The following is a description of a gene set: species: Mus musculus The process in which a relatively unspecialized immature germ cell acquires the specialized features of a mature female gamete. Mouse Gene Set: GOBP_OOCYTE_DIFFERENTIATION, and this is the list of marker genes: Tut4, Rps6ka2, Foxo3, Igf1, Tdrd1, Ctnnb1, Bcas2, Oog1, Dnmt3a, Washc5, Pabpc1l, Wee2, Sohlh1, Ehmt2, Insl3, Zp3, Kmt2d, Sirt2, Pde5a, Zar1l, Pld6, Tdrd6, Ezhip, Tdrd5, Lgr5, Rec8, Tut7, Tdrd7, Zfx, Fbxo5, Ptk2b, Dazl (deleted in azoospermia-like), Nppc, Pde3a (phosphodiesterase 3A, cGMP inhibited), Bcl2, Cdc25b, Dmrt1, Edn1, Ppp2r1a, Oosp2, Kmt2b, Washc1, Npm2, Dnmt3l, Dmc1, Trip13, Bnc1, H3f3a, Gdf9, Ythdc2, Wdr77, Ereg, Ccnb1, Plcb1, Sohlh2, Lsm14b, Rxfp2, Dcaf13, Shb, Atm, Cyp51, Brca2, Dnmt3b, Aurka, Ednra, Ythdf2, Meioc, Tdrkh, Wnt4, Zar1, Inhbb, Zglp1, Mos, Grb14, Npr2